Given this list of marker genes FSCN1, POR (NCBI Gene Id 96440), EVI5, HORMAD1, SMU1, GJD2, ZNRF4, LRRC20, SOX2, SEPHS2, NSG1, FMNL1, PRAP1, TMEM143, NCKAP1, LY75, PCDH20, GRIN1, PIP4K2C, PTPA, TMEM120B, PKIA, SPTAN1, RAB30, JDP2, SERPINE1, CYP7B1, PWP2, HOXD13, TWF2, MIS12, RNF181, TPM2, PDZK1IP1, TENM2, AKR1D1, MRPS7, CAVIN1, MRPS18B (mitochondrial ribosomal protein S18B), FTL, ACAD9, ORM1, AK4 (NCBI Gene Id 387851, adenylate kinase 4), WASHC2A, SRF, PPP1R16B, TCF21, SH2B1, CDK2AP1, SPIC, INTS14, MCOLN2, STK10, PCSK6, WDR5, CAMK2B, CKS1B, PPTC7, SRM (spermidine synthase), SERBP1, BBLN, ORMDL1 (ORMDL sphingolipid biosynthesis regulator 1), GATC, SLC7A10, UBE2Z, ANKRD12, ENO2, ITSN1, PFDN6, DNMT3A (DNA methyltransferase 3 alpha), AMPD2, COX17, FABP4, EYA2, CASQ2, TUBB2A, SIX5, TBCD, PGLYRP2, CRHR2, ALKBH5, MCM3AP, HMGCL, POLR1C, SAMD8, CDCA4, DSCAM, TBX3, LAD1, CPS1, RHBDF1, SEC61A2, C14orf180, HEXIM1 (HEXIM P-TEFb complex subunit 1), IMP3, SLC6A8, EBI3, TUSC2, HK1, USH2A, RANBP10, BLMH, GNA13, LHX9, PYGO2, TNFRSF17, HINT1, ITPR3, KDM2B, LIMD1, CCDC115, FEN1, TCF3, RDH12, NAP1L3, UBXN2B, MFSD14A, ALPG (alkaline phosphatase, germ cell), MIA, SLC25A10, TMEM51, DDB2, CD72, RUVBL1, SPICE1, SQLE, DHPS, CLSTN1, RANBP3, SLC22A5, HACD2, TIMM17B, IMPACT, CCDC93, TEAD2, ETHE1, RPS6KB1, IRF4, CCL24, CDC42SE2, MT2A, HELQ, SERPINC1, VTI1B, ZNF808, SPC25, FCHO1, CYP2C18, ZNF274, AATK, BUD31, SMOC2, NKX2-2, KCNJ14, CIITA, SGCD, KCTD4, PARD6B, CPT2, DIABLO, PGAM1, GRIA4, RBMX, CREG1, CPA1, HLA-DMA, COPS7B, SCNN1B, KATNBL1 (katanin regulatory subunit B1 like 1), SF3A2, STRN, DCLRE1B, TAF1C, TPRA1, FOXD3, TPM3, STMP1, HACD3, NSDHL, CDCA5, POLR2I, MAP3K11, PLA2G15, CDK9, TMEM128, AGO2, TBX5, SIRT2, RPS21, FANK1, ADGRD1 (NCBI Gene Id 283383), PEA15, BMP7, ARHGEF12, IFITM2 (NCBI Gene Id 10581), BCL3, KIF1C, CLDN15 (NCBI Gene Id 245814), UBE2H, THAP11, here is a description of the gene set: species: Homo sapiens from publication Amit I, Garber M, Chevrier N, Leite AP, Donner Y, Eisenhaure T, Guttman M, Grenier JK, Li W, Zuk O, Schubert LA, Birditt B, Shay T, Goren A, Zhang X, Smith Z, Deering R, McDonald RC, Cabili M, Bernstein BE, Rinn JL, Meissner A, Root DE, Hacohen N, Regev A (PMID 19729616) Genes up-regulated in comparison of dendritic cells (DC) stimulated with Pam3Csk4 (TLR1/2 agonist) at 4 h versus DC cells stimulated with Gardiquimod (TLR7 agonist) at 4 h. Human Gene Set: GSE17721_PAM3CSK4_VS_GADIQUIMOD_4H_BMDC_UP mouse primary BMDCs were stimulated with tlr ligands and gene expression changes were profiled on Affymetrix arrays